The following is a description of a gene set: species: Homo sapiens Type II diabetes mellitus Human Gene Set: WP_TYPE_II_DIABETES_MELLITUS, and this is the list of marker genes: GK, PRKCZ, SLC2A2 (solute carrier family 2 member 2), PRKCD, PHKA2, KCNJ11, PIK3R5, PDX1, ADIPOQ, MTOR, CACNA1A, IRS1, MAPK8, TNF, SLC2A4, INSR, INS-IGF2, SURF1, MAFA, IKBKB, MAPK1, SOCS4